Given this list of marker genes Slc19a1, Ptgs2os, Eif2ak2, Gdi1, Abhd17a, Aars2, Trim62, Phb2, Tlr11, Dhx9, Nagk, Tbk1, Cd160, Irgm2, Znfx1, H2-T23, Stmp1 (short transmembrane mitochondrial protein 1), Myd88 (NCBI Gene Id 17874, myeloid differentiation primary response gene 88), Ifi203-ps, Irf2, Srebf1, Cyba, Ifi207, Tax1bp1, Hpx (hemopexin), Gfi1, Nop53, Clpb, Tlr6, Stat5b, Irak2, Cd14, Nlrp6, Arg1, Ninj1, Ipo5, Tlr1, Tmem126a, Prkce, Ppt1, Gbp3 (guanylate binding protein 3, NCBI Gene Id 99898), Hspd1, Gimap5, Ifi213, Aurkb, Zc3hav1, Rftn1, Nlrp1b, Usp27x, Nr1d1, Clnk, Pum2, Pycard, Lats2, Mefv, Pik3ap1, Gkn2, Slamf6, Zcchc3, Rab11fip2, Smpdl3b, Ywhag, Parp1, Ticam2, Dhx33, Treml4, Cptp, Hspa1b, Ripk2, Polr3c, Card9, Pomc, Rps19, Gps2, Mavs, Ufd1, Tlr2, Hcfc2, Raet1e, Ifi214, Lrrc14 (leucine rich repeat containing 14), Rnf144a, Rab7b, Polr3f, Becn1, Ulbp1, Otud4, Cd300a, Nploc4, Lrch4, Ticam1, Nfkbil1, Atat1, Trim15, Tlr8, Traf3ip3, Znrf4, Zdhhc3 (zinc finger, DHHC domain containing 3), Nod2, Xiap, Hmgb1, Gm12250, Cadm1, Epg5, Xrcc6, Klrc1, Mark4, Mr1, Klrd1, Ly96, Zdhhc9, Nono, Lag3, Arrb2, Tkfc, Cd74, F2rl1, Trim31, Ywhae, Polr3g, Klk7, Prkaa1, Tab1, Irgm1, Ifi204, Mmrn2, Rbm47, Pum1, Fpr2, Usp15, Cd300ld3, Irak1, Fpr-rs4, Esr1, Gbp2b, Washc4, Fbxl2, Slc15a4, Ppp2ca, Matr3, Nectin2, Dpp4, Irf1, Lamp1, Tlr9, Lrrc19, Usp17le, Trim32, Tasl, Kat5, Sqstm1, Tspan6, Il12a, Cgas, Banf1, Fcnb, Unc13b, P2rx7, Rab34, Lgr4, Ifi211, Ifi209, Slc22a13, Irf7, Nod1, Nr1h4, Riok3, Rtn4, App, Sh2d1b2, Nlrp1a, Tarbp2, Sin3a, Nlrp10, Trem3, Traf6, Polr3d, Tlr12, Xcl1, Sirt2, Irf4 (NCBI Gene Id 20734), Ube2k, Lgals9, Plcg2, Clec4n, Rasgrp1, Zdhhc5 (NCBI Gene Id 98978), Kcnj8, Ubqln1, Cactin, Fpr-rs3, Tomm70a, Hmgb2, Ltf, Sfpq, Ncr3-ps, Ereg, Rasgrp4, Polr3b, Rigi, Il21, Clec4e, Kcnk13, Trim41, Colec12, Lsm14a, Gbp7, Appl2, Wdfy1 (NCBI Gene Id 73607), Sash1, Nek7, Phb1, Sarm1, Lamp2, Oas3, Rela, Akirin2, Nfkbiz, Raet1d, Irf3, Cd300lf, Nlrc4, Ifi205, Klre1, S100a8, Mapkapk2, Cd24a, Klrc2, Tlr7, Oas1f, Il17a (interleukin 17A), Ddx3x, Txk, Pvr, Ap1g1, Pla2g5, Trim30c, Traf3, Tlr4, Oas1d, Reg3g, Tyrobp (NCBI Gene Id 22177), Prkdc, Tlr5, Alpk1, Bcl10, Zdhhc4, Igtp, Grn, Src, Oas1b, Trim12a, Ppp6c, Havcr2, Cd86, Nfkbia, Sh2d1a, Vav1, Itch, Irak3, Rps6ka3, Tyro3, Mfhas1, Stat5a (NCBI Gene Id 20850), Emilin1, Klri1, Zdhhc1, Cpt1a, Ikbke, Prkd1, Slc46a2, Nlrc5, Trim30a, Brcc3dc, Btk, Cd40lg, Klrc3, Tifa, Rsad2, Pqbp1, Flot1, Hrg (histidine-rich glycoprotein), Trim56, Parp9, Klk5, Clec7a, Klri2, Pcbp2, Oas1e, Erbin, Tnfaip3, Plscr1, Trim12c, Tnf, Casp4, Lyplal1, Klrb1c, Trim11, Hexim1, Nlrc3, Dhx58, Ptpn11, Tlr3, Fbxo38, Ogt, Trem2, Lats1, Arf6, Ifi35, Sec14l1, Wnt5a, Cav1, Trim6, Tnip1, Xrcc5, Lrrfip2, Med1, Appl1, Klrk1, Zdhhc18, Tnip2, Casp1, Sh2d1b1, Cxcl1, Ffar2, Oas1c, Pdpk1, Akt1, Ankrd17, Rnf185, C1qbp, Smpdl3a, Trim3, Pik3r1, S100a9, Rbm14, Lyn, Nmi (N-myc (and STAT) interactor), Sting1, Ccdc134, Ecsit, Fadd, Peli3, Slc15a3, Oas1g (2'-5' oligoadenylate synthetase 1G), Crtam, Spi1, Il18rap, Cd274, Rnf170, Ptprs, Inava, Lacc1, Nlrx1, Nlrp3, Il17f, Tirap, Rnf34, Nr1h3, Tnip3, Rnf125 (ring finger protein 125), Gpatch3, Tifab, Lbp, Znrf1, Gbp5, Oas1h, Cd36, Tlr13, Klhl22, Adam8, Gm15441, Chuk, Trim30d, Trim5, Ifi208, Gsdme, Oas1a, Trim30b, Oasl1, Mbl2, Fpr-rs7, Elp6, D1Pas1, Zbp1, Acod1, Fcna, Ifi203, Syk, Ly86, H2-M3, Aim2, Naglu, Csnk1a1, Mapkapk3, Cd180, S100a14, Trim25, Dab2ip, Pgc, Mmp12, Prkca, Casp6, Gimap3, Pja2, Letmd1, Tril, Bmp6 (NCBI Gene Id 28108), Unc93b1, Spsb3, Fosl1, Otulin, Emilin2, Rnf135, Ptpn22, Bpifb1, Il12b, Peli1, Gramd4, Brcc3, Trex1, Fpr-rs6 (NCBI Gene Id 321020), Zdhhc12, Ifi206, Gbp2, Cd226, Rnf115, Hspa8, Mndal, Pspc1, Mapk8, Ifih1, Slc15a2, Usp29, Ddx60, Usp50, Map3k7, Scimp (SLP adaptor and CSK interacting membrane protein), Mif, Hsp90aa1, Ap3b1, Gpr108, here is a description of the gene set: Mouse Gene Set: GOBP_POSITIVE_REGULATION_OF_RESPONSE_TO_BIOTIC_STIMULUS Any process that activates or increases the frequency, rate, or extent of a response to biotic stimulus. studied in species Mus musculus